Given this list of marker genes COL9A1, COL4A3, COL18A1, COL5A1 (NCBI Gene Id 1289), COL6A3, COL1A1, COL22A1, COL4A4, COL11A1, COL25A1, COL17A1, COL20A1, COL2A1, COL21A1, COL5A2, COL27A1, COL16A1, COL24A1, COL4A5, COL6A2, COL14A1, COL5A3, COL4A6, COL10A1, COL9A3, COL15A1, COL4A2, COL19A1, COL28A1, COL23A1, COL26A1, COL4A1, COL6A5, COL6A6, COL8A2, COL7A1, COL13A1, COL9A2, COL1A2, COL8A1, COL11A2, COL12A1, COL3A1, COL6A1, here is a description of the gene set: Human Gene Set: REACTOME_COLLAGEN_CHAIN_TRIMERIZATION studied in species Homo sapiens Collagen chain trimerization